Given this list of marker genes NR1H2, TTC1, PAM, CYYR1, NMNAT2, CYP4F2, KCTD5, TRIM8, ETS2, C18orf63, KCNIP1, LPIN3, C4orf33, MAP2K4, CYP2C18, GATA4, CCDC69, SEL1L, EMSY, GABBR2, NPTX2, SCYL3, SNX13, FOXQ1, ERG, MMP15, CTSF, HMGCR, PTGFRN, KHDC3L, DLX3, WWTR1, PIK3R5, EXOC2, CHD1, UPB1, FYN, GEN1, NPM1, SYNPO2, HOOK3, EIF4E2, ENOSF1, ADGRE5, HMG20A, GPM6B, WWC2, PRDM14 (NCBI Gene Id 63978), USP30, UBR1, PRRC1, KLF14, LCE3D, DYRK1A, here is a description of the gene set: from publication Chen Y, Wang X (PMID 31504780) Human Gene Set: MIR3690 Genes predicted to be targets of miRBase v22 microRNA hsa-miR-3690 in miRDB v6.0 with MirTarget v4 prediction scores > 80 (high confidence targets). studied in species Homo sapiens